The following is a description of a gene set: To analyze gene expression in in regulatory T cell precursors that develop in the absence of a functional Foxp3 protein as compared to that of normal regulatory T cells Genes up-regulated in T conv versus T reg FOXP3 knockout. species: Homo sapiens Human Gene Set: GSE6875_TCONV_VS_FOXP3_KO_TREG_UP from publication Lin W, Haribhai D, Relland LM, Truong N, Carlson MR, Williams CB, Chatila TA (PMID 17273171), and this is the list of marker genes: ORM2, NSMCE4A, RETREG1, GABPB2, ELL, TMUB1, PLXNB2, ZBTB22, RAB3B, ESYT2 (extended synaptotagmin 2), ZBED4, PNP, AKNA, DIRAS2 (DIRAS family GTPase 2), GTF2A1L, PCDHB1, RASA2, NEMP1, FOXO4, STK38, SDC1, PCNT, GAREM2, AP5B1, RHEBL1 (RHEB like 1), ARMC6 (armadillo repeat containing 6), SART1, CD2 (CD2 molecule), MYOZ3, OTX1, CDC25B, NPRL2, MYL9, PTPRC, ATF5, YEATS4, MRC2, SLC26A2, STK40, MYOZ1, RHOA, TBX6 (T-box transcription factor 6), F2RL2, CD200, TRIM59, NPFFR2, CLVS2, TMEM71, RDH12, BEND5, PDE2A, SSBP2, LMBRD1, LACTBL1, A1CF, GPC6, STYK1, ITGB7, TMEM270, MUC1 (mucin 1, cell surface associated), CCDC159, STPG3, ELAVL3, SEMA6B, LAPTM5, TUBB4B (NCBI Gene Id 10383), BCL6, ANGPT2, ZNF296, ARPC5, RFXANK, PGPEP1, SATB1, MIXL1, SSH1, ADD1, EMP3, MANF, IGHG1, MYADM, CRB3, PTBP3, CMTM2, HEXB, PLXNA2, CCM2, ADGRL3, GMFG, SLCO5A1, HVCN1, GPR12, PRSS54, FOXD2, RASGRP3 (RAS guanyl releasing protein 3), C6orf132, MMP11, ZNF354B, GPRIN1, SMAD1, STRBP, ZBTB8A, KCNE2, DAG1, SALL1, FAU, CA3, SVOP, ABHD16A, OVGP1, ARRDC5, S1PR4, MEX3B, SHC3, GLT6D1, EPB41L5, IFITM10, DGCR8, FAM3C, KCTD14, HCAR2, DCAF11, VAMP5, RERG, PBX2, COL6A1, GIMAP4, PIK3CG, GRPR, FAM177A1, RPA1, CPM, FOXK1, CSF3R, MARCO, HLA-DRB1, KRTCAP2, GUCD1 (guanylyl cyclase domain containing 1), IGSF3, MAN1A1, FCHSD2, CACNA1H, HMGCS1, GPD1L, PROK2, ITPKC, TMC5, VPREB3, DOCK11, COMMD8, ASB11, PLEKHO1, PAXX, RPTN, AKT3, RBP4 (retinol binding protein 4), KPNA4, BPIFB1, SH3BP5L, ZNF710, TNFRSF12A, CHD5, NFKBIA, SLAMF1, MESP2, TMEM86B, CACNA1D (NCBI Gene Id 776), VIL1, LRIG1, MED11, CRAT, SPRR2A, ARF1, PLEKHG1, PM20D1, TNIK, KIRREL1 (kirre like nephrin family adhesion molecule 1), SCML4, PPM1N (NCBI Gene Id 147699), RAC3, RIMS4, STXBP3, RAD17, DIXDC1, NDRG1, MYH1, PGAP1, FBXO17, FAIM, RIPOR2, CXCR6, SUPT4H1, FBXL8, B4GALNT2, LRRC1, SLC10A4, SLC6A14, CTHRC1, TUSC2